The following is a description of a gene set: Human Gene Set: REACTOME_IRON_UPTAKE_AND_TRANSPORT Iron uptake and transport species: Homo sapiens, and this is the list of marker genes: ATP6V1C2, HMOX1, ATP6V0D1 (NCBI Gene Id 9114), ATP6V0E1, FBXL5, ATP6V0C, SLC46A1, STEAP4, ATP6V1G3, ATP6V1B2, SLC22A17, CAND1, UBC, ATP6V1D, FTMT, ATP6V1H, NEDD8, ATP6V1E2, ABCG2, ATP6V0D2, ATP6V0B, CYBRD1, ATP6V0A2 (ATPase H+ transporting V0 subunit a2), FTH1, TF, LCN2, ATP6V1C1, SLC11A2, CUL1, HMOX2 (NCBI Gene Id 3163), ACO1, ATP6AP1, CP, ATP6V1E1, UBB, IREB2, ATP6V1G2, ATP6V1G1, FTL, TFR2, SLC40A1, ATP6V0A4, TCIRG1 (NCBI Gene Id 8845), UBA52, GLRX3, STEAP3, TFRC, HFE, ATP6V1A, ATP6V1F, ATP6V1B1, FLVCR1, RPS27A, ATP6V0E2, MCOLN1, SKP1, HEPH, ATP6V0A1